Given this list of marker genes Kcnk4 (NCBI Gene Id 16528), Kcnk6, Kcnk3, Kcnk18, Kcnk16, here is a description of the gene set: electronically inferred by orthology from the curated human pathway Reactome Pathway: Tandem pore domain potassium channels studied in species Mus musculus This event has been computationally inferred from an event that has been demonstrated in another species.<p>The inference is based on the homology mapping from PANTHER. Briefly, reactions for which all involved PhysicalEntities (in input, output and catalyst) have a mapped orthologue/paralogue (for complexes at least 75% of components must have a mapping) are inferred to the other species. part of: Potassium Channels